Given this list of marker genes ABCC8, KCNJ11, here is a description of the gene set: Reactome Pathway: Defective ABCC8 can cause hypo- and hyper-glycemias studied in species Homo sapiens part of: ABC transporter disorders ATP-binding cassette sub-family C member 8 (ABCC8) is a subunit of the beta-cell ATP-sensitive potassium channel (KATP). KATP channels play an important role in the control of insulin release. Elevation of the ATP:ADP ratio closes KATP channels leading to cellular depolarisation, calcium influx and exocytosis of insulin from its storage granules. Defects in ABCC8 can cause dysregulation of insulin secretion resulting in hyperglycemias or hypoglycemias. Specific phenotypes observed are noninsulin-dependent diabetes mellitus (NIDDM; MIM:125853), permanent neonatal diabetes mellitus (PNDM; MIM:606176), transient neonatal diabetes mellitus 2 (TNDM2; MIM:610374), familial hyperinsulinemic hypoglycemia 1 (HHF1; MIM:256450) and leucine-induced hypoglycemia (LIH; MIM:240800).